Given this list of marker genes EDA2R, DMXL2 (Dmx like 2), USP48, PROK2, NDUFAF8, MIA3, PDX1, EIF2AK3, RFC2, POLD1, HLA-DRB1, IRS1, BMP6, NDUFS8, LIG4, PRSS1, STUB1, CLIP2, TP53, NEUROD1, YIPF5, FKBP6, MT-TS2, KCTD1, SLC37A4, SLC29A3, RAC1, FXN, CEP290, CAV1 (caveolin 1), SNORD116-1, LHX1, NDUFA6, PTRH2, NDUFA1, GPR101, SCAPER, GFM2, CNOT1, MKKS, TLR8, CNBP, PRKAR1A, CTNS, POLG2, WDPCP, GATA6, GJB4, STOX1, TWNK, MT-TL1, MEG3 (NCBI Gene Id 55384), LRBA, TRPV6, UBR1, CDKN2A, IGF2BP2 (NCBI Gene Id 10644), DNMT1, EIF4H, EIF2S3, ELN, ZFYVE26, MICU1, NDUFAF1, OPA1, NSMCE2, SLC40A1 (NCBI Gene Id 56414), IARS1, TINF2, IFT74, GYG1 (NCBI Gene Id 2992), POC1A, APPL1, CORIN, FBN1, MST1, HNF1B, GLIS3, LEMD3, INS, GPR35, CASR, LMF1, BBS10, NDUFA11, CEL, NPAP1 (nuclear pore associated protein 1), EDA, PTPN1, SARS2, SPINK1, NDUFV1, GTF2IRD1, NDUFS6, LMNA, ITPR3, PLAGL1, DUT, MT-CO1, ABCB4, MEF2A, APOE, LIPE, FMR1, TRMT10A, FOXP3, MT-ND5, FOXP1, PLIN1, PCBD1, LRP6, MT-ND4, MT-CO2, GATA3, PSTPIP1, MEN1, IER3IP1, NDUFB11, NDN, CLCNKB, BAZ1B, CTNNB1, LSM11, ALMS1, CTC1, AEBP1, POLG, CPE, PCYT1A, NDUFAF3, SEMA4D, CCDC28B, MT-TC (NCBI Gene Id 4511), MT-TQ, TMEM126B, IGF1R, GPD2, BMP2, ZBTB20, SLC25A4, ARL6, FOS, NDUFAF4 (NCBI Gene Id 29078), DYRK1B, CYP19A1, MT-TV, RNU7-1, HJV, TERT, SCLT1, CPA1, RABL3 (RAB, member of RAS oncogene family like 3), HAMP, STAT1, ATRX, NDUFS3, HERC2, ADAR, WRAP53, AR, SNORD115-1, SNRPN, ADA2, DLK1, ZFP57, SLC12A3, ZNRF3, PALLD, ZMPSTE24, NOTCH3, LZTFL1, SAMHD1, CISD2, SIN3A, MT-ND3, BRCA1, NOP10, BBS4, RNASEH2C, CTRC, MAGEL2, GJB3, GLRX5 (glutaredoxin 5), ABCC8, MAPK8IP1 (NCBI Gene Id 9479), HYMAI, NDP, GCGR, MOG, NPHP1, RNASEH2B, THRB, HNF1A, ITCH, DNM1L, ATM, NR3C1, MMP2, MT-TK (NCBI Gene Id 4566), MLXIPL, PNPLA6, SPI1, MT-CO3, KRAS, PPP1R15B, LMNB2, SLC2A2, IL18BP, IFT27, NPM1, IGKC, SMPD4, LIPC, IRS2, GOSR2, POLR3A, FLT1, IL6, METTL27, PEX10, TCF4, TMEM270, NDUFS1, CELA2A (NCBI Gene Id 63036), PWAR1, OCA2, DNAJC30, NDUFS2, PDE4D, USB1, SMAD4, VPS37D, TYMS, SLC19A2, TERC, LEP, ELMO2, BBS12 (NCBI Gene Id 166379), PARN, MTNR1B, STX1A, CFTR, PTPN22 (NCBI Gene Id 5779), MKS1, RTEL1 (regulator of telomere elongation helicase 1), CIDEC, PRKACA, IFT172, RFX6, BBS7, DNASE2, HMGA2, TTC8, INSR, NDUFAF2, FOXRED1, BSCL2, EFL1, PLCD1, PALB2, AMACR, SBDS, PWRN1, NHP2, BBIP1, MT-ND1, RTL1, NDUFB3 (NADH:ubiquinone oxidoreductase subunit B3), APOA5, IFIH1, KCNJ11, TCF7L2, CAVIN1, PI4KA, ACBD6, NEUROG3 (NCBI Gene Id 50674), ZNF668, MANF, MT-ATP6, HLA-DQA1 (NCBI Gene Id 7946), HMGA1, SDCCAG8, CARS1, CAT, MT-TH, RETN, MT-ND6, BBS9, LEPR, BUD23, NDUFV2, MT-CYB, PCNT, MT-TE, NDUFS4, IL2RA, MKRN3, BBS1, MC4R, STAT3, CDH23, BLK, GJA1, NUBPL, BRAF, SIM1, TTC7A, TIMMDC1, NDUFB9, CTLA4, AGPAT2, PNPLA2 (NCBI Gene Id 57104), AIP, BLM, CBLB (Cbl proto-oncogene B), PAX4, MAFA, ADRA2A, NAF1, LIMK1, NDUFAF5, GTF2IRD2, BRCA2 (BRCA2 DNA repair associated), PIK3R1, CEP19, KDSR, TBL2, CP, MT-TF, HLA-DQB1, NDUFS7, HNF4A, GTF2I, MT-ATP8, AKT2, DNAJC3, TRIM32, PRSS2, FOXC2, PPARG, PDCD1, AIRE, CFAP418, TTPA, DCAF17, WRN, MMP14, DKC1, DNAJC21, TKT, MT-TW, GCK (NCBI Gene Id 2645), HBB, ENPP1, NDUFB10, RRM2B, BBS2, WFS1, NCF1, HFE, MT-ND2, PEX1, IGHG2, POLA1, MPV17, SLC30A8 (solute carrier family 30 member 8), PTF1A, KLF11, RNASEH2A, BBS5, PLAAT3 (NCBI Gene Id 11145), PEX6 (NCBI Gene Id 5190), USP8, TREX1 (three prime repair exonuclease 1), PPP1R3A, HR, XRCC4, here is a description of the gene set: Human Gene Set: HP_DIABETES_MELLITUS studied in species Homo sapiens Diabetes mellitus A group of abnormalities characterized by hyperglycemia and glucose intolerance.